Given this list of marker genes F2RL1, COL6A2, GRIA3, APOBEC2, INPP5K, TIMP2, DNAJB4 (DnaJ heat shock protein family (Hsp40) member B4), KCNH2, SPINK4, SYNRG, NAGA, RAB17, SPATA6, LGALS4, TGM2, TRAFD1, PLEKHB2, RFX2, TEC, RAPGEF4, SLC22A1, BCL2, EIF2AK2, ARFGAP3, PRCC (proline rich mitotic checkpoint control factor), LHCGR, PLEKHA5, RANBP10, SOX13, HLA-DOA, STK40, PKP3, RCVRN (recoverin), TEK (TEK receptor tyrosine kinase), SP4, PKD1, CD79B, HOXA3, SIT1, SPPL2B, USP3, MAPK8IP3, SIAH1, RBM4B, ABCD1, BCL6, TRIM13, CEL, ATP9A, PSAP, MAP2K6, AKAP7, ZBTB20, MROH1, AGRN, CD1D (CD1d molecule), CXCR4, SPA17, CA2, DENND2B, ARID3B, CALR, SUGP2, BTC, MX1, REXO1, MTFR1L, PMPCA, F9, APP, ZNF260, MCOLN2, MPL, CYP2E1, CCDC152, FGD3, GUCA1A, SGPL1, FUT9, STAT5A, RAB33B, GNG3, PEA15, KRT1, DIAPH1, ELMOD3, TLR7, RAB5B, ACTR1B, DLX1, NCOA3, JARID2, CTNNAL1, RPL12, SQOR, ABCG1, PDE4B, GCG, USP2, WNT7B, CNTRL, MYOM2, SYT9, ARHGEF25, MYL6, NQO1, FOXK1, MFGE8, AZI2, RPL22, CCKBR, MAP4K3, LDAF1 (lipid droplet assembly factor 1), HRH2, COLQ, ULK2, MSL2, RALGPS2, TRAF2, AKIRIN1, UBXN6, PI4K2A, KITLG, SLFN12, RPL37A, PAPSS2 (NCBI Gene Id 9060), IL3RA, FBXW4, TLE4, POMC, SUB1, SOX4, USF2, HGF, ITGB3, PHF1, ADRB2, NEDD4L, COL6A1, PPFIBP2, GRINA, MAP1LC3A, BLOC1S1, COQ10A, FRMD8, SKAP2 (NCBI Gene Id 8935), CANT1, BRWD3, IP6K1, ASGR2, SEMA4F, EXOC7, CYP3A43, WNT11, RFXANK (NCBI Gene Id 8625), DLGAP4, EYA2, MAP7, TNNC2, ADGRL1, SURF4, PCSK7, ARF3, WBP1 (WW domain binding protein 1), GABBR1, TCF20, CYTH3, NECAP1, RECK, UNC119, ADGRG3, MYH7, TCN2, HIP1R, LALBA, RETREG2, ZYG11B, SEC11C, N4BP1, KLC4, APOBEC1, PHRF1, HCFC1R1, GBF1, HR, APC, TFPI2, MEST, ZNF292, LMO2, UBE2E3, PGLYRP1, KIF3C, B4GALT1, YJU2, SLC39A4, INSM1, NRTN, BSDC1, ACVRL1, here is a description of the gene set: Human Gene Set: GSE15930_NAIVE_VS_24H_IN_VITRO_STIM_CD8_TCELL_UP from publication Agarwal P, Raghavan A, Nandiwada SL, Curtsinger JM, Bohjanen PR, Mueller DL, Mescher MF (PMID 19592655) Genes up-regulated in comparison of CD8 T cells at 0 h versus those at 24 h. studied in species Homo sapiens Differentiation of naive CD8 T cells into cytotoxic effector cells requires three distinct signals- antigen (signal 1), costimulation -B7-1 (signal 2) and cytokine, either interleukin-12 or interferon-a/b (signal 3). Interaction of naive CD8 T cells with antigen and B7-1 programs cell division and proliferation whereas the presence of cytokines- IL-12 or IFNa/b promote survival, differentiation and memory establishment. In the absence of signal 3, the cells interacting with antigen/B7-1 undergo tolerance induction. The objective of this study was to elucidate the mechanisms how the provision of signal 3 promotes differentiation and averts tolerance induction in CD8 T cells. Trichostatin A is a pharmacological agent that inhibits histone deacetylase activity, hence regulating chromatin structure and gene expression and differentiation in many cell types. Gene signature profiles of IL-12, IFNa/b and trichostatin A stimulated cells were compared to elucidate the molecular mechanisms of gene regulation. Oligonucleotide microarray analysis is carried out to determine the extent and molecular nature of the CD8 T cell differentiation program induced by IL-12 or IFNa/b in concert with antigen and B7-1 signal.